Given this list of marker genes Il1rapl1, Tlr2, Tlr4, Tlr11, Il18rap, Tlr13, Sarm1, Il1rl1, Il1rl2, Il1rapl2 (interleukin 1 receptor accessory protein-like 2), Il1rap, Il18r1, Il1r1, Bst1, Tlr12 (NCBI Gene Id 384059), Cd38, Tlr6, Tlr1, here is a description of the gene set: studied in species Mus musculus Mouse Gene Set: GOMF_NADPLUS_NUCLEOSIDASE_ACTIVITY_CYCLIC_ADP_RIBOSE_GENERATING Catalysis of the reaction: NAD+ + H2O = ADP-D-ribose + nicotinamide + H+, in a two step reaction: first an ADP-ribosyl cyclase reaction to synthesise cyclic ADP-ribose, followed by a cyclic ADP-ribose hydrolase reaction to generate (linear) ADP-ribose.